The following is a description of a gene set: electronically inferred by orthology from the curated human pathway Reactome Pathway: ADP signalling through P2Y purinoceptor 12 species: Mus musculus This event has been computationally inferred from an event that has been demonstrated in another species.<p>The inference is based on the homology mapping from PANTHER. Briefly, reactions for which all involved PhysicalEntities (in input, output and catalyst) have a mapped orthologue/paralogue (for complexes at least 75% of components must have a mapping) are inferred to the other species. part of: Signal amplification, and this is the list of marker genes: Gnb5, Gng3, Gng5, Gng10, Gnat3, Gngt1, Gnb2, Gnb3, Gng8, Gng4, Gng7, Gngt2, Gng11, Gnai1